The following is a description of a gene set: A region of a chromosome at which a DNA double-strand break has occurred. DNA damage signaling and repair proteins accumulate at the lesion to respond to the damage and repair the DNA to form a continuous DNA helix. Human Gene Set: GOCC_SITE_OF_DOUBLE_STRAND_BREAK studied in species Homo sapiens, and this is the list of marker genes: MBTD1, SIRT6, WAS, XRCC4, CYREN, SMARCA5, VCP, UFL1, ATM, UIMC1, TP53BP1, SETMAR, STK38, ZBTB7A, SIRT7, H2AX, TONSL, HUS1, NABP2, ARPC1A, NHEJ1, SMARCAL1, PELI1, POLL, DDB1, PARP1, DGCR8, TIMELESS, CGAS, ACTR2, DYNLL1, PHF1, MMS22L, HUS1B, PARP3, SMCHD1 (NCBI Gene Id 2490), APLF, PNKP, RNF8 (ring finger protein 8), RPA1 (NCBI Gene Id 6117), KAT5, WDR70, MDC1, POLQ, RNF138, ARPC2, TOPBP1, MRE11, FH, CHD1L, RAD51, RPA4, AIM2 (absent in melanoma 2), SLF2, SMC5, RHNO1, SLF1, RAD18, PRPF19, PAXX, KDM4D, MAD2L2, IFFO1, WRAP53, SHLD1 (shieldin complex subunit 1), HELB, RNF168, HTATSF1, ARPC3, SMARCAD1, RIF1 (NCBI Gene Id 55183), SAMHD1, RAD17, ACTR3, RPA2, SMC6, RPA3 (replication protein A3), SHLD2, RAD50, ARPC4, INIP, RBBP8, ATF2, SHLD3, ZGRF1, POLH, ASF1A, ARPC5, CNTD1, ESCO2, RNF169, NABP1, RFWD3, TP53, EPC1, LMNA, INTS3 (NCBI Gene Id 65123), DMC1, NBN